The following is a description of a gene set: from publication Chen Y, Wang X (PMID 31504780) Genes predicted to be targets of miRBase v22 microRNA mmu_miR_151_3p in miRDB v6.0 with MirTarget v4 prediction scores > 80 (high confidence targets). Mouse Gene Set: MIR_151_3P species: Mus musculus, and this is the list of marker genes: Nkx6-3, Hrnr, Ago2, Armc8, Triobp, Rfx3, Atp2a2, Afg2a, Ntsr2 (NCBI Gene Id 18217), Clec4b2, Ago3, Map3k20, Npas3, Ppcdc, Casp12, Mocs2, Eif3a, Hipk3, Sim1, Adam10, Serpinb1c, Ugt8a, Nipal2, Nsun4, Clasp2, Pls3, Tnc, Eif2a, Thoc2, Upp2, Spock1, Pcdh7, Slc6a2, Btbd1, Brwd1